Given this list of marker genes GREM1, PLXNB1, MN1, MIR9-1, MIR138-1 (microRNA 138-1), MIR675, EIF2AK2 (eukaryotic translation initiation factor 2 alpha kinase 2), AXIN2, BCL2, NELL1, SMAD3, SFRP1, ATRAID, NF2, here is a description of the gene set: Any process that stops, prevents or reduces the rate or extent of osteoblast proliferation. Human Gene Set: GOBP_NEGATIVE_REGULATION_OF_OSTEOBLAST_PROLIFERATION studied in species Homo sapiens